Given this list of marker genes TLR6, TLR5 (toll like receptor 5), UBE2N, TLR2, JUN, TIFA (NCBI Gene Id 92610), TLR9, TLR1, UBE2V1, TLR4, TLR7, IL1A, TRAF6, TLR10, MYD88, NFKB1, TLR8, IRAK1, here is a description of the gene set: species: Homo sapiens MYD88 distinct input-output pathway Human Gene Set: WP_MYD88_DISTINCT_INPUTOUTPUT_PATHWAY